Given this list of marker genes TERC, SFTPA1, SFTPA2, WNT4, FLCN, PARN, DSP, STN1, RTEL1, MUC5B, SFTPC, ATP11A, ABCA3, CCR2, DPP9, PI4KA, YARS1, TTC7A, TERT, FAM13A, SREBF1, here is a description of the gene set: studied in species Homo sapiens Multiple pulmonary cysts The presence of multiple lung cysts. Human Gene Set: HP_MULTIPLE_PULMONARY_CYSTS